Given this list of marker genes IL23A, CCR6, ADAM19, BLK, CAPG, NPDC1, JAML, RARG, RORC (NCBI Gene Id 6097), MGLL, GPR25, LST1, SLAMF1, IL23R, DPP4, TRDV2, IL4I1, SCART1, here is a description of the gene set: Human Gene Set: HE_LIM_SUN_FETAL_LUNG_C4_TH17_CELL species: Homo sapiens from publication He P, Lim K, Sun D, Pett JP, Jeng Q, Polanski K, Dong Z, Bolt L, Richardson L, Mamanova L, Dabrowska M, Wilbrey-Clark A, Madissoon E, Tuong ZK, Dann E, Suo C, Goh I, Yoshida M, Nikolić MZ, Janes SM, He X, Barker RA, Teichmann SA, Marioni JC, Meyer KB, Rawlins EL (PMID 36493756) Th17